Given this list of marker genes KANK1, BIN2, ETV6, GOLGA4, KDR, here is a description of the gene set: part of: Signaling by PDGFR in disease species: Homo sapiens In addition to activating missensse and in-frame deletion mutations, PDGFRA and PDGFRB are also subject to low frequency gene fusion events arising from chromosomal rearrangements. To date there are about 35 identified PDGFRA or B fusion partners, with PDGFRB being the more common partner. Although some of the PDGF fusions proteins are cytosolic by virtue of removal of the PDGFR transmembrane region (TMD), a number of fusions retain the TMD and are linked to the plasma membrane. The most common transmembrane fusion partner of PDGFRA and PDGFRB is ETV6 (also known as TEL1), a transcriptional repressor with known ability to homodimerize. Reactome Pathway: Signaling by membrane-tethered fusions of PDGFRA or PDGFRB